The following is a description of a gene set: Human Gene Set: WP_CANCER_IMMUNOTHERAPY_BY_PD1_BLOCKADE Cancer immunotherapy by PD-1 blockade species: Homo sapiens, and this is the list of marker genes: IFNG, CD8A, JUN, NFKB1, CD3G, LCK, NFATC2, PTPN11, NFATC4, PDCD1, HLA-DRB1, CD3E, BATF, NFAT5, PDCD1LG2, HLA-A, CD8B, CD3D, ZAP70, NFATC1, NFATC3, CD274, STAT3